The following is a description of a gene set: studied in species Homo sapiens Human Gene Set: GOBP_SUBSTRATE_ADHESION_DEPENDENT_CELL_SPREADING The morphogenetic process that results in flattening of a cell as a consequence of its adhesion to a substrate., and this is the list of marker genes: LAMA5, ITGAV, AXL, LPXN, MDK, ABL1, WASHC2C, SPRY4, PIK3R1, RCC2 (NCBI Gene Id 55920), ITGB7, CALR, KANK1, FZD7, VAMP3, BRAF, EFNA5, EPHA1, ARHGEF7, TACSTD2, P4HB, FGG, FGB, LAMC1, DAB2, CRKL, MERTK, ITGA8, PARVB, LIMS2, C1QBP, EFNA1, APOA1, FERMT3, ANTXR1, FBLN1, MYADM, MICALL2, ILK, FN1, GBP1, DOCK1, MYOC, ITGA4, RREB1, UNC13D, HTN1, DMTN, CSPG5, PKP2, TYRO3, SRCIN1, RAB1A, S100A10, ITGB3, CASS4, ACTN4, BVES, POSTN, PTK2, CORO1C, NEDD9, ARPC2, FZD4, FGA, PARVG, CRK, PARVA, LIMS1, FER, RAC3, OLFM4, HAS2, ITGB1BP1, PEAK1, AKIP1, RADIL, TRIOBP, FERMT2, AP1AR, PXN, NTN4, PDPN, LAMB1, CDC42, EPHB3, KIF14, TESK1, FLNA, SRC (NCBI Gene Id 6714), TEK, SRGAP2, PREX1, RHOA, NRP1, CIB1, RAC1, DOCK5, MELTF, CARMIL1